Given this list of marker genes ANGPTL7, HBEGF, CHL1, SLC24A5 (solute carrier family 24 member 5), HOPX, CCL23, SF3A2, SCARB2, RREB1, ELL2, C1QL1, NFKB2, SLC16A5 (solute carrier family 16 member 5), SSNA1, LMO1, MICAL3, IQSEC2 (IQ motif and Sec7 domain ArfGEF 2), AFF2, KRT16, CST7, ALAS2, NAPA, NFATC2IP, ATP6V1G1, KEL, HOXC6, MEF2D, AURKB, NDRG1, S100A10, CAMK2B, MBP, EMP3, UGCG, CD160, NFKBIA, WDR62, TFDP2, GABRP, LITAF, EDC4, GPR3, IRS2, SLC39A8, IGFBP1, CRHR2, GREM1, ADM, TNIK, NCKIPSD, H2AC6, GRIN1, VPS8, FCAR, TBCB, PGAP4, CELA2A, P2RY6, PDE2A, ETS2, GADD45A, EIF1AX, ACOX1, HSF4, CCR6, MT2A, GHRH (NCBI Gene Id 2691), MSC, ZNF136, CUL7, CXCR4, ATP8B1, RAI14, TFPI, TRIM27 (NCBI Gene Id 5987), CXCL8, CD83, MAP2K1, TRAF1, FCGR2B, NR3C2 (NCBI Gene Id 4306), GAL3ST1, ACO1, IL4R, TJP1, GCAT (NCBI Gene Id 23464), KDM7A, POU1F1, RELB, GAL, CCL7, CD34, ZBTB22, SLPI, TFF3, IFRD1, RASGRF1, CEBPD, CRK, FCGR2A, USP20, DLEC1, GRIP2, JAK3, CCL3, CDK2, MC2R, IL15RA, SEMA7A, MMP9, PAX3, AOPEP, CSF2RB, SIAH1, PTHLH, DNAH17, INA, GLE1, MFAP3, IL9R, EHD1, TDRD7, G0S2, OBSL1, PTGER2, KDM6B, CYB5A, SRSF8, PHYHIP, SQSTM1, TUB, TYMP, NR2F1, UBE2S, RHOQ, FOXN3, IL3, PPP3CC, ANGPT1, MT1B, SMAD7, CMKLR2, AUH, ERC2-IT1, KLK10, GNRH2, CTSL, VCP, CNIH3 (cornichon family AMPA receptor auxiliary protein 3), LYPD3, RGL1, IER3, ADAM8, UNC5B, TUBB2A, AKR1B1, GSDME, STX11, GSTT4, KRT86, RARRES1, FLT3LG, ENO2, ATP2B2, AMHR2, AHR, GYPC, DUSP5, ACOT7, PDGFRA, BTG1, RPS6KB1, LAMP3, SPINK4, SULT4A1, LY75, TXN, CSNK2A2, FAM110B, FGFR2, SIX6, MX1, MUC6, CPNE6, ADAM19, PNRC1, TGM3, QPCT, FST, ZBTB17, SLC17A4, SYN1, APOBEC3G (apolipoprotein B mRNA editing enzyme catalytic subunit 3G), IL2RG, H6PD, NRP2, CCL4, N4BP1, RNFT2, CASP7, here is a description of the gene set: Monocyte-derived dendritic cells (DC) and macrophages (MΦ) generated in vitro from the same individual blood donors were exposed to five different pathogens, and gene expression profiles were assessed by microarray analysis. Responses to Mycobacterium tuberculosis and to phylogenetically distinct protozoan (Leishmania major, L. donovani, Toxoplasma gondii) and helminth (Brugia malayi) parasites were examined, each of which produces chronic infections in humans yet vary considerably in the nature of the immune responses they trigger. from publication Chaussabel D, Semnani RT, McDowell MA, Sacks D, Sher A, Nutman TB (PMID 12663451) species: Homo sapiens Genes down-regulated in untreated dendritic cells (DC) versus DCs exposed to parasite L. donovani. Human Gene Set: GSE360_CTRL_VS_L_DONOVANI_DC_DN